The following is a description of a gene set: studied in species Homo sapiens The presence of autoantibodies in the serum that react against neutrophils. Human Gene Set: HP_ANTINEUTROPHIL_ANTIBODY_POSITIVITY Antineutrophil antibody positivity, and this is the list of marker genes: UBE2L3, FASLG, DOCK11, ELANE, TNFSF4, FAS, IL10, BACH2, HLA-DRB1, SERPINA1, TNFAIP3, BANK1, TLR7, CLPB, JAZF1, CTLA4, MECP2, CR2, CTNNB1, IRF5, IRAK1, HLA-DPA1, ARPC1B, DNASE1 (deoxyribonuclease 1), FCGR2B, IGHG1, TNIP1, FCGR3B, ETS1, DEF6, EIF2AK4, TAP2, DNASE1L3, RFXANK, PDCD1, ICOSLG, GFI1, C4A, ITCH, BLK, PXK, PRTN3, STING1, TREX1, TLR8, C4B, CASP10, STAT4, KIAA0319L, SRP19 (signal recognition particle 19), SPP1, ITGAM, MPV17, PTPN22, TCIRG1 (T cell immune regulator 1, ATPase H+ transporting V0 subunit a3), HLA-DPB1, SAT1